The following is a description of a gene set: studied in species Mus musculus TAK1-dependent IKK and NF-kappa-B activation Mouse Gene Set: REACTOME_TAK1_DEPENDENT_IKK_AND_NF_KAPPA_B_ACTIVATION, and this is the list of marker genes: Uba52, Ikbkb, Nkiras1, Ager, Nkiras2, Ubc, Rela, Nfkbia (NCBI Gene Id 18035), Lrrc14, Uba52rt, Irak2, Tab2, Casp8, N4bp1, Usp18, Tab3, Irak1, Rps27a, S100b, Nfkb2, Ubb, Ube2v1, Nlrc5, Tab1, Alpk1, Tifa, Nlrx1, Ikbkg, Hmgb1, Ube2n, Map3k7, Nfkbib, App, Traf6, Chuk, Traf2, Usp14, Nfkb1